Given this list of marker genes LRBA, ATM, IGHM, RMRP (NCBI Gene Id 6023), CARD11, FLII, IKBKG, PTPN22, IFNGR1 (interferon gamma receptor 1), TNFRSF13C, CFHR3, ARHGEF1, FCGR3B, TNFSF4, ZNF341, NFKB2, C1QC, POLD1, PTEN, PSMB9, PRKCD, TCF3, TRMU, CCNO, KRAS, TERT, C8A, TGFB1, FASLG, PLCG1, POLD3, GTF2E2, CAVIN1, PSMB10, TNFSF12, KDM6A, CDSN, GTF2H5, LYN, C4A, NAE1, PSMB4, CD19 (NCBI Gene Id 930), NFE2L2, CD28, MUC5B, CBLB, CFB, AARS1, BANK1, CD3E, LIG4, EXTL3, HELLS, GPC3, MECP2, STAT2, TNFRSF13B, KNSTRN, LAT, RASGRP1, ADAM17, MTOR, BCL10, UNC13D, PSMB8, TTC7A, SERPING1, IL2RA, CFP, CD81, DNASE1L3, TLR8 (toll like receptor 8), RAG2, C4B, IVNS1ABP, EGFR, SPI1, C8B, RPA1, MCTS1, UNG, FAS (NCBI Gene Id 355), ERCC3, SETX, CDCA7, POU2AF1, MGAT2, BTK, CARS1, LMNB2, STX11, SPP1, SKIC2, IL12A, ADAMTS3, DSG1, PIGT, POMP, SRP54 (signal recognition particle 54), CD3D, HYOU1, IL10, IRF2BP2, PLCG2, CR2, ICOS (NCBI Gene Id 29851), IGLL1, STIM1, MS4A1, TARS1 (NCBI Gene Id 94887), PIK3R1, TNFSF15, RNF113A, RNF31, OTULIN, BLNK, RFX5, FOXP3, IL6ST, ATP6AP1, THBD, SAT1, TONSL, NLRP1, AK2, GBA1, LAMTOR2, HLA-DQA1, PACS1, ADA2, TOM1, DEAF1, PLVAP, MPLKIP, LMNA, BLK, TNFRSF11A, ADA, PTPRC, PRIM1, JAZF1, SH2D1A, TYK2, IL21R, SLC46A1, DOCK11, KMT2D, SCARB2, SP110, IL21, C1QA, NTRK1, IKZF1, MAGT1, IRF8 (NCBI Gene Id 3394), CD247, STXBP2, CNBP, TPP2, CFH, STING1, SASH3, TNPO3, RTEL1, FCGR2B, FAT4, XIAP, CORO1A, REL, FLNA, IRAK4, MOGS, CPLX1, MAP3K14, SYK, CTNNBL1, ARPC5, KRT5, ORAI1, GPR35, CD79A, TYMS, CCBE1, IRAK1 (interleukin 1 receptor associated kinase 1), LRRC8A, CCND1, STAT6, VPS33A (VPS33A core subunit of CORVET and HOPS complexes), CASP8, SKIC3, BLM, IL6R, PGM3 (phosphoglucomutase 3), SPPL2A, COL1A1, ETS1, SPINK5, CISD2, TIMM8A, DCLRE1C (NCBI Gene Id 64421), IQSEC2, IL12RB1, MTHFD1, CTLA4, NELFA, AICDA, MSN, TREX1, PXK, MVK, CSNK2A1, IKBKB, OAS1, LCK, ITK, CD3G, ZEB2, KIAA0319L, C5, IL2RG, CIITA, SON, POLE, SPIB, ZAP70 (NCBI Gene Id 7535), FNIP1, ITCH, BACH2, SHARPIN, KRT14, CD27, PSTPIP1, RNF168, LETM1, RIPK1, SFTPC, IGKC, CD79B, VPS45, TNFAIP3, CFD, IL2RB, CARD9, CD40LG, MALT1, NHLRC2, ITGAM, PIK3CG, C1QB, WAS, PEPD, GPC4, CFHR1, CARD10, EPG5, RFXANK, KRT74, ATP6AP2, HLA-DQB1, PDCD1, RNU4ATAC, KLHDC8B, LIG1, TNFRSF1B, MST1, CXCR4, GALK1, TP53, SEC61A1, DNMT3B, ERCC2, CTPS1, STAT4, CD46, SLC35C1, UHRF1, ZBTB24, SEMA4D, IRF1, C9 (complement component 9), SAMD9L, B2M (beta-2-microglobulin), MASP2, C3, PMM2, TRNT1, SIK3, CD70, CASP10, CTBP1, SFTPA2 (NCBI Gene Id 83342), SLC7A7, RAI1, SH3KBP1, MMEL1, CARMIL2, IPO8, RAC2, CFI, RFXAP, KRT9, TCF4, NFKBIA, SLC19A1 (NCBI Gene Id 6573), NCKAP1L, PIK3CD, NSD2, SLC5A6, PRF1, C1S, C6, CD55, MYD88, STAT5B, TLR7, MAN2B1 (mannosidase alpha class 2B member 1), DRG1, DOCK8, SMARCAL1, ALB, FBXL4, TNIP1, NFKB1, ICOSLG, JAK3, IFIH1, COG6, C7, PIGG, IL7R, IGHG2, TNFRSF9 (TNF receptor superfamily member 9), IRF5, SLC39A7, NRAS, RAD50 (RAD50 double strand break repair protein), STAT3, COL7A1, DNASE1, HLA-DRB1, RAG1, MYSM1, NSMCE3, TFRC, ALG12, CD40, UBE2L3, NBN, NHEJ1, TCN2, IGHG1, SLC25A13, ELANE, RBM8A, here is a description of the gene set: An abnormality of the humoral immune system, which comprises antibodies produced by B cells as well as the complement system. Abnormality of humoral immunity studied in species Homo sapiens Human Gene Set: HP_ABNORMALITY_OF_HUMORAL_IMMUNITY